Given this list of marker genes NRXN1, HEG1, SMARCC2, NTRK2, PTPN1, CARMIL1, ZNF629, MAP1A, ZBTB37, PCBP3, ING5, ZCCHC2, SPEG, SERTAD4, TMCC2, NUP160, SPDYE5 (NCBI Gene Id 442590), RXRA (NCBI Gene Id 6256), MANEA, NKAIN1, UBXN10, ZSCAN31, ZBTB7C, PITPNC1, CCBE1, CSF1, SLC24A4, TENM4, APOBEC2, CASZ1, SLC25A30, SETD3, PLXNA2, ELF3, LBX2, IGF1, KSR2, EHD3, FAM168A, GPATCH2L, APOLD1, SPR, SPDYE1, AGAP1, EPPIN-WFDC6, GABBR2, IGFBP5, TNFRSF13B, CHD3 (chromodomain helicase DNA binding protein 3), AGFG2, GRIA3, SFMBT1, PHKA1, ZNF514, M6PR, ELFN2, CDH11, FBXW11, PKHD1 (NCBI Gene Id 5314), EYA2, LRP11, TARS3, TVP23C, PDE3B, ZNF618, PLCB1, AADACL3, LRCH4, CNOT9, NMUR2, SMAP2, SAE1, NR2F1, CCNT1, SPDYE3, MYO5A, UBE3D, SCYL2, GMEB2, ZFYVE27, CHRNA1, LYN, here is a description of the gene set: from publication Chen Y, Wang X (PMID 31504780) Genes predicted to be targets of miRBase v22 microRNA hsa-miR-4723-3p in miRDB v6.0 with MirTarget v4 prediction scores > 80 (high confidence targets). Human Gene Set: MIR4723_3P studied in species Homo sapiens